The following is a description of a gene set: Hiatus hernia The presence of a hernia in which the upper part of the stomach, i.e., mainly the gastric cardia protrudes through the diaphragmatic esophageal hiatus. species: Homo sapiens Human Gene Set: HP_HIATUS_HERNIA, and this is the list of marker genes: C1R, NUP133, GLIS3, TRAF7, ATAD1, ATP7A, YRDC, WDR73, ALDH18A1, TP53RK, TGFB3, TPRKB, GLRA1, GLRB, MED12, NUP107, SLC2A10, CHST14, NIPBL, TNXB, TCF4, LAGE3, GON7, ADAMTSL2, MYH11, ADAMTS2, COL5A1, CAMTA1, COL1A1, COL5A2, SLC6A5, WDR4, ZNF699 (zinc finger protein 699), EXT2, OSGEP, ZBTB7A, PORCN, GPHN